Given this list of marker genes ADORA2A, BLNK, PRRC2A, EAF2, MSI2 (NCBI Gene Id 124540), JUND, FSTL5, PMEL, SUGP2, SPTY2D1, PDE4D, FGF12, MGAT5B, APOBEC4 (apolipoprotein B mRNA editing enzyme catalytic polypeptide like 4), LDB2, FAM117A, PAM, EGR2, FZD2, NRXN1, CLCA3P, DPYSL2, PRDM1, ITPRIP, TSPAN13, NR6A1, NEUROG1, CSF3 (colony stimulating factor 3), BTK, NRXN3, NFIA, MYBPC1, PTEN, H3-3B, CRYZL1, RRAS, FCHSD1 (NCBI Gene Id 89848), ZNF362, GAB2, MAP2K6, TCP11L2, CSRNP3, DLX1, PROKR2, TLL2, DLG2, PATZ1, ARF6, COL25A1, IRX4, TSNAX, TCF12, CNNM4, OPA3, VPREB3, UBE2S, LMO3, GRIA3 (NCBI Gene Id 2892), RCAN1, LRCH4, CDX2, ADORA1, GPR85, H2BC3, SKIDA1, C10orf71, PIM2, PTHLH, PIGT, C12orf57, GRHL3, FOXG1, H2BC14, VSNL1, RTTN, H3C3, THRA, BCO2 (NCBI Gene Id 83875), TRAF3, ITPR3, CDK2, H2AC14, OR10A5, ALDH1A1, LRRN1, CHD6, PCDH8, CADM1, MTUS1, BDNF, GPR4, H2BC21, THAP2, EYA1, CRISP1, AMER1, SERTAD4, TAS2R13, CBFA2T2, SH3BGRL, ROGDI, BRINP3, H2BC12, SESN3 (sestrin 3), PRRX1, PFKFB1, LYN, ODAPH, TSC22D3, NFYB, SFRP2, HOXC11, ARMC6, ARMCX4, LRMDA, SUCNR1, SPRR2B, POU2F3, WNT6, ALK, ETV1, CADM2, TSPYL2, KANSL1L, NSMCE3, MRAS, FGF20, H3C2, NDP, ZSCAN20, PRICKLE2, ITSN1, DLGAP4, SRF, LPL, RANBP3L, TMOD2, PPP2R2B, FOXP2, MAB21L2, TPD52, ATP2A2, DIS3L, ASCL3, HOXA10, MMP1, TCEAL1, HOXC5, SH3GL3, TP53INP2, REL, DNAH5, SYVN1, ZNF428, CCDC107, PLPPR2, ADNP2, ZHX2, KIF13A, MED16, GPM6A, COL23A1, EIF1AX, SCML4, CCDC116, MPPED2, H2AC20, UQCC2, FZD4, PAX6, SYNPR, TMSB4XP8, SCOC, ARHGAP4, IQCB1 (IQ motif containing B1), SLC25A12, TMSB4XP4, SREBF2, OTX2, EPHB3, HOXB6, PCYT1B (NCBI Gene Id 9468), SIAH3, GPC4, H2AC4, CDX4, DMD, TRAF3IP2, HNF1B, TMCC1, H2AC12, HOXB8, TRERF1, LCOR, HOXA7, ANXA2, LINC00649, TBXAS1 (NCBI Gene Id 6916), H2AC21, DPYSL3, TAS2R40, NRAS, POU3F4, CEP41, RAB26, RHOB, ATF7IP, NXPH1, ZNF423, E2F3, H2AC1, CCDC71L, TCERG1L, SLC25A35, FGF14, RPP21, CD86, ZNF516-DT, IL25, ZFC3H1, FOXP1, CXXC4, TTI2, STX12, SLC6A15, PRDM10, PPP2R3A, HPCAL4 (NCBI Gene Id 51440), DAPK3, CSRNP1, SP6, CRACR2B, HDAC9, LIPG, GPRC5B, HOXD11, IGSF21 (NCBI Gene Id 84966), H2BC1, EBF1, NRL, LHX6, TWIST1, STAT4, TSC1, SLITRK6, SEMA6C, TOP1, EHF, VGLL3, CES5A, UPK3A, H2BC4, H2AC6, CD180, FBXO24, SPIB, SEC22A, DUSP6, CCN1, MID1, TMSB4XP6, ABTB2, HOXB4, C2CD5, ATP8B1, KCNN3, BCORP1, here is a description of the gene set: Human Gene Set: OCT_Q6 studied in species Homo sapiens Genes having at least one occurrence of the motif TNATTTGCATN in the regions spanning 4 kb centered on their transcription starting sites. This matches the transcription factor binding site V$OCT_Q6 (v7.4 TRANSFAC).